Given this list of marker genes IL3, CBFB, RUNX1, ELF1, LIFR, here is a description of the gene set: RUNX1 regulates transcription of genes involved in interleukin signaling Human Gene Set: REACTOME_RUNX1_REGULATES_TRANSCRIPTION_OF_GENES_INVOLVED_IN_INTERLEUKIN_SIGNALING species: Homo sapiens